Given this list of marker genes AOAH, HK3 (hexokinase 3), NXN, CHRD, LGALSL, RRAD, COQ2, POMZP3, DELEC1 (deleted in esophageal cancer 1), SERINC1, BMP3 (bone morphogenetic protein 3), TLR4, ZBTB18, AGR2 (NCBI Gene Id 10551), AVPR1A, TBXAS1, DENND1A, PARD3, APOBEC3A, UBB, DAPK2, SLA (NCBI Gene Id 6503), GRIK5, DSC3, REG1A, AR, GSTT2, SLC1A6, NHLH2, ATP12A, HOXD10, FBXL5, CCL23, MMP15, SEC14L1, FHL3, TPSG1, LIMK2, PPP1R15A, FTH1, PLSCR2, GPD2, EML4, MPHOSPH8, ZMIZ1, ZNF669, GLTP, LGALS4, H2BC21, EFNB2, AMPD3, CACNA1G, ULK1, MRFAP1L1 (NCBI Gene Id 114932), H3C7, PIK3CB, ADIPOR2, SMAD7, NEUROD6, COPZ2, F11R, CACNA1F, PODNL1, IL5, GCNT2, DENND1B, PHOX2A, PTGER3, TRIB1, MPO, CAMK1D, CDHR5, LAMP2, POLB, SLC6A6, LAPTM4A, ACSM3, SLC22A4, SPINK1, CNR2, ANXA1, KLF5, ITIH4, INSR, MKRN1, HCK, FUCA1, CUX2, EGLN3, ADAM11, NOTCH2, GRIA2, MCOLN1 (mucolipin TRP cation channel 1), TRPC6, ADAMTSL3, TGFBR2, CRY1, NR4A2, ITPRID2, ACACB (NCBI Gene Id 32), PTAFR, CHRDL1, ALOX15, C1S, NOTCH1, INPP5A, NAA60, FPR1, CHST8, PDE4A, MTMR3, GSTM4, ICOS, PAPOLB, CD244, CCN3, PSG3, DCBLD2, GRB10, MUC5AC, KLHL25, B3GALT2, PTGER2, TFDP2, FOXN2, ACSBG1, SYNE1, SLC36A1, WIF1, SMAD5, NLRX1, JARID2, CXCL1, KCNMB1, EPM2AIP1, TRPV4, RRAGD, HSPA1L, SLC27A6, ZNF200, DMC1 (NCBI Gene Id 11144), CD302, LRP6, H3C12, MANSC1, CCNA1 (NCBI Gene Id 8900), NRXN1, MAP2K7, DOK2, STAB1, JAG1, FUS (NCBI Gene Id 406232), PITPNM3, ARRB1, ALOXE3, RHOB, TMEM212, DUSP1, ADORA2B, TNFRSF1A, SEC14L2, TNFRSF1B, ADAMTSL4, ID2B, PTEN, PDE4C, ADGRE5 (NCBI Gene Id 976), APCS, CACNB2 (calcium voltage-gated channel auxiliary subunit beta 2), HRH4, PTGES, WIPI1, IFITM1, TNFRSF9, KLK14, CREG1, FRAS1, SDCBP, CHMP3, CHRM3, PKNOX2, SMR3A (submaxillary gland androgen regulated protein 3A), MCOLN3, MMP25, FGD2, CA4, PSTPIP2, TLL1, CDA (cytidine deaminase), GPR35, MPP1, CYSLTR1, COL11A1, THEMIS2, HIPK1, H2BC7, CKLF, PDZD7, G3BP2, here is a description of the gene set: Genes up-regulated in comparison of eosinophils versus B cells. studied in species Homo sapiens from publication Jeffrey KL, Brummer T, Rolph MS, Liu SM, Callejas NA, Grumont RJ, Gillieron C, Mackay F, Grey S, Camps M, Rommel C, Gerondakis SD, Mackay CR (PMID 16474395) In the present study we used Affymetrix oligonucleotide microarrays to produce gene transcription profiles for the major leukocyte types in humans. This comprehensive dataset enabled us to not only establish which genes were expressed in each leukocyte type, but also which genes were expressed in each subset after activation. The used of a comprehensive dataset of gene profiles from all the major human leukocyte subsets enabled a novel and powerful means for identification of genes associated with single leukocyte subsets, or different immune paradigms. Human Gene Set: GSE3982_EOSINOPHIL_VS_BCELL_UP